Given this list of marker genes NANOG, HNF1B, SOX17, EOMES, DKK1, SOX2, POU5F1, MESP1, here is a description of the gene set: species: Homo sapiens Human Gene Set: GOBP_ENDODERMAL_CELL_FATE_SPECIFICATION The cell fate determination process that results in a cell becoming capable of differentiating autonomously into an endoderm cell in an environment that is neutral with respect to the developmental pathway; upon specification, the cell fate can be reversed.